The following is a description of a gene set: Human Gene Set: CTR9_TARGET_GENES Genes containing one or more binding sites for (CTR9) in their promoter regions (TSS -1000,+100 bp) as identified by GTRD version 20.06 ChIP-seq harmonization. from publication Yevshin I, Sharipov R, Kolmykov S, Kondrakhin Y, Kolpakov F (PMID 30445619) species: Homo sapiens, and this is the list of marker genes: VEZF1, RNU6-1, TLDC2, PGK1, EYS, EDEM1, XXYLT1, ALAS1, SNORA3B, ERICH2-DT, NOP14-AS1, ZNHIT2, TPM4, BAZ1A, MYL6, ABCA7, BRIP1, TCERG1, H2BC21, ENSG00000267174, RPS15AP11, AMD1, VNN3P, TAPT1, SFPQ, HNRNPC, SNX22, MYADM-AS2, MIR4530, EFEMP2, SRSF7, PRKAG1, CHASERR, MIRLET7BHG, PABPC1 (poly(A) binding protein cytoplasmic 1), SOX9-AS1, PDCD6IPP2, TPT1, RNA5S17, ZEB2, BAG6, HNRNPU, RPL41, MTFR2, SCG5, FBXL5, BOLA1, SCAT8, TLR5, CSDE1, ZDHHC8, RBM39, TRA2B, TMEM138, ZNF207, ENSG00000212144 (U8 small nucleolar RNA, NCBI Gene Id 124900421), SYCE2, H2AC6, CCNL1, RPL9, LRRC59, POMT1, SLPI, DAPK3, IQCN, TRHDE-AS1, ERCC3, MIR5695, GAS5 (NCBI Gene Id 60674), YWHAZ